Given this list of marker genes TOMM20, MCUR1, TIMM23B (NCBI Gene Id 653252), TOMM22, SLC8B1, TIMM17A, CPT1A, SLC25A33, MPC1L, MICU3, CPT2, BHLHA15, MPC1, UCP3, TIMM23, SLC25A23, TOMM70, UCP1, SLC25A32, HSPA4, ABCB8, SLC25A37, LETM2, DNLZ, CCDC51, SLC25A24 (NCBI Gene Id 92093), SAMM50, SLC25A26, SLC25A1, GRPEL2, SLC25A36, AIFM1 (apoptosis inducing factor mitochondria associated 1), LETM1, SLC25A52, MCU (mitochondrial calcium uniporter), SLC39A8, SPG7, ITPR1, SLC30A2, MPC2, VDAC1, SLC25A6, HSPD1, SLC25A39, SLC25A41, ADCY10, SLC25A28, GFER, SFXN3, TIMM17B, PAM16, MRPL18, TIMM50, MICU2, COL6A1, MRS2, SLC25A31, SMDT1, DNAJC15, GHITM, TOMM7, AFG3L2, CPT1B, TIMM44, SLC25A29, SLC25A2 (solute carrier family 25 member 2), PSEN2, SLC25A4, TOMM20L, UCP2, SLC25A21, TOMM40, SFXN4, SLC25A40, SLC25A16, MAIP1, PNPT1, HSP90AA1, SLC8A3, SLC25A15, TST, SLC25A51, SELENON, MCUB, VDAC2, ABCB10, SLC25A3, HSPA9, SLC25A20, GRPEL1, SLC25A38, SFXN1, SLC41A3, CHCHD4, ROMO1, PMPCB, ABCB7, TOMM40L, DNAJC19, SLC25A5, MICU1, SFXN2, TIMM21, SFXN5, here is a description of the gene set: Human Gene Set: GOBP_MITOCHONDRIAL_TRANSMEMBRANE_TRANSPORT The process in which a solute is transported from one side of a membrane to the other into, out of or within a mitochondrion. species: Homo sapiens